The following is a description of a gene set: species: Homo sapiens from publication Chen Y, Wang X (PMID 31504780) Genes predicted to be targets of miRBase v22 microRNA hsa-miR-448 in miRDB v6.0 with MirTarget v4 prediction scores > 80 (high confidence targets). Human Gene Set: MIR448, and this is the list of marker genes: RNF19A, GRB2, PABPC4L, YIPF2 (NCBI Gene Id 78992), CC2D2A, CRTC1, AUTS2, CBLL2, GFPT2, RICTOR, FAM168B, TRMT11, SYN1, SPTBN4, ZNF286B, SLC4A4, VGLL3, FMR1, BCL2, TCERG1L, CPSF2 (NCBI Gene Id 53981), PTF1A, DZIP1L, RAI14, SLC9A9, BCL11A, CPEB2, SATB1, PPP1R12A, WWP1, KDSR, KANK4, LEPROTL1 (NCBI Gene Id 23484), VASH2 (NCBI Gene Id 79805), ATXN7, BICC1, TTN (NCBI Gene Id 7847), MRAP, FRMD6, TBX3 (NCBI Gene Id 91834, T-box transcription factor 3), RAB11FIP2, MON2, FOXR2, SBNO2 (NCBI Gene Id 22904), PLSCR5 (phospholipid scramblase family member 5), EEF1AKMT2, PSMA8, ACSL6, MDFIC, IFFO2, GAN, WRNIP1, SPTLC3, TLCD4, DSTN, FBXO48, PDE4D, PRTG, AMPH, BMPR1B, C9orf40, KCNJ16, IGF1R, COL19A1, KCNB1, AZIN1, FOXO3, PCDH7, MPPED2, SALL4, DOC2A, PPP6C, ILRUN, DTX3, TAOK1, UNC5A, RALGPS2, ZNF135, ANKRD42, ZEB2, ENPP4, OGFOD1, SERTAD2, CNTNAP1 (contactin associated protein 1), ERRFI1, LRRC8B, FER1L5 (NCBI Gene Id 90342), ALDH8A1, ADD1, FOXD1, HS3ST5, PHF3, INO80D, SNTB2, SEMA3A, SH3KBP1 (NCBI Gene Id 94010), ROR1, IGLON5, OTX2, ZNF454, ZZEF1, PIGA, IKZF1, OR2L13, SOCS5, ABLIM3, DCC, TBC1D19, PRKAA1, SPRY2, CADM2, VEZF1 (NCBI Gene Id 7716), ATOSA, SOCS2, C18orf63, PTPN14, UTRN, TIMMDC1, RPS6KA5, RIGI, SLCO5A1, MBTD1, PCDH8, SS18 (NCBI Gene Id 6760), PDS5A, TAGLN3 (transgelin 3), GPHN, FBXL17, SGPP1, KCNA1, PIP4P2, FBXO30, PAXBP1, EPHA4, KCTD1, KIAA1210, TAF1, PLA2G4A, IRX2, SHC1, PDE6C, RABGAP1, OXR1, NFIA, ADO, MFHAS1 (multifunctional ROCO family signaling regulator 1), SETD9, ATG5, SMURF1 (SMAD specific E3 ubiquitin protein ligase 1), NLGN1, GPM6A, TTLL7, ZNF644, FANCF, ZNF711 (NCBI Gene Id 7552), SIX4, ETNK1, RUNX2, FAXC, C17orf75, OSMR, SKI, IRS2, AURKA, HEY2, MGAM, ADAMTS8, PHKB, RTN4, RBFA, PIK3R1, PHF13, FNDC1, CFAP119, ING2, SLC16A7, ZNF677, UNC5C, DACT1, DSG1, STIM2, GTF3C3, ANK3, TCEAL1, HECW2, KCTD9, RB1CC1, AGO3, LYSMD4, CATSPERE, FBXO8, PTBP1, MAGEA6, DMD, AMER2, DNAJB11, TFPI2 (tissue factor pathway inhibitor 2), PAIP1, FAM216B (family with sequence similarity 216 member B), UBE2W, PRDM2, BTAF1, XYLT2, EFCAB7, SOX6, CNKSR2, FERMT2, TIGD1, PDE12, MEF2C, NFATC2, CREB5, ATAD2B (NCBI Gene Id 54454), NBEA, BACH2, RNFT1, SLAIN2, GRIP2, PPIP5K2, PRKG1, HIPK1 (homeodomain interacting protein kinase 1), PKHD1 (PKHD1 ciliary IPT domain containing fibrocystin/polyductin), KREMEN1, BAHCC1, C21orf91, TBC1D8B, NAV2, SLC9A4, UBFD1, VSTM2A, SCN3A, FBXO28, CRY1, PELI1, KLF5, KCNIP4, ABHD13, MAP2K6, CACNA1C, GLCE, RTN4RL1, SMAP1, KLHL5, ADD3, KIF3A, TESK2, RCOR1, SORL1, KIF7, BTG3, CAPRIN1, ZCCHC14, SGTB, RBM41, FAM168A (NCBI Gene Id 23201), RNGTT, ANO5, ARID1A, FBXO33, FXR1, SGK3, CEP97, TLR4, ZNF148, KCNH7 (NCBI Gene Id 90134), ZDHHC15, ZDHHC6, GDF6, ADAM23, STARD13, DSC1, BPNT2, DTNA, CAP1, CLCN5, NRG3, DYNLT3, LGSN, MPC1, SPOPL, CNTN5, MAGEA3, ZFP3, KCNK3, HCFC2, ELF2, GPR158, CCDC152, MED13L, RAB12, HECTD2, AGAP1, ZBTB43 (zinc finger and BTB domain containing 43), BMAL1, CBFB, NFIC, NPR2, TXNDC11 (thioredoxin domain containing 11), ZBTB34, JOSD1, LHFPL6, SLC12A2, TRMT9B, ANO8, IPO7, ZNF521, SYT4, RAB7A, N4BP2L2, TPCN1, SRSF11, CDK19, SGIP1, PTPRE, ACTN4, TACC1, DAGLA, DAAM1, NPTN, TTYH3, TMOD2, DESI2, PDE10A, HPS6, USP6NL, PIGV, ARMH4, ACVR2A, RHEBL1, PFN2, DOCK9, GEM, DCAF5, SH3TC2, KCND1 (potassium voltage-gated channel subfamily D member 1), STIMATE, SYNPO2, DPP4, FHIP2A, ZNF660, GABRB2, KCNA4, GRHL3, KCNMB2, RCCD1, REST, HDLBP, PRKAB2, BMPR1A, VWA5B2, SF3B1, TMSB4X, KCNQ4, DARS1, DCLK1, DDX18, ENKUR, LRRC57, SESTD1, DENND1B, ZDHHC2 (zinc finger DHHC-type palmitoyltransferase 2), RNF7, E2F3 (E2F transcription factor 3), UTP23